The following is a description of a gene set: from publication Chen Y, Wang X (PMID 31504780) species: Homo sapiens Human Gene Set: MIR449B_3P Genes predicted to be targets of miRBase v22 microRNA hsa-miR-449b-3p in miRDB v6.0 with MirTarget v4 prediction scores > 80 (high confidence targets)., and this is the list of marker genes: TMEM178B, SLC17A5, FRAT1, PCDHA6, LTBP3, ZDHHC9, MMGT1, FGF13, P4HA2, KMT5B, IP6K1, CREBRF, VANGL1, DLX3, WASL, YWHAZ, PPP2R5C, ZNF711, GNA13, PCDHAC2, TMEM65, TM9SF2, PCDHA1, ZMYND11, GPR161, PCDHA7, RWDD1, CAP2, BLTP1, U2SURP, GRIK2, GAP43, DYNC1LI2, PIGU, SFTPA2, SEPTIN11, ZSWIM5, RB1CC1, POGZ, PCDHA4, PLXNA1, NKX2-2, PCDHA2, PCDHA11, CSRNP3, CBL, CLDN1, RSBN1, PPP3CB, MTF2, SLC43A2, PHF20L1, NFAT5, ZMYM2, LPL, ZNF385B, SORT1, IPO8, NSG2, MSI2, PTPN9, LRP8, PHACTR4, ATP8A2, PCDHA13, DEPP1, SRBD1, PCDHA12, TMCC1, GPR137C, SLITRK3, PCDHA10, SCAI, SRSF11 (serine and arginine rich splicing factor 11), TSPYL1 (TSPY like 1), STXBP6, COLEC12, GLCCI1, METTL14, TSNAX, RAB1A, ZNF518A, FOXD2 (NCBI Gene Id 2306), WDR6, XPO4, SAYSD1, BMAL2, SLC5A12, ZBTB25, UPRT, NR2C2, ZNF17, KIF1B, CDC37L1, GARIN1A, GNAZ, SLC39A10, ATP6AP1, NPPC, UCP3, GABARAP, NTPCR, DDC, STON2, UBA6, EPHA7, SMAD4, PCDHA5 (NCBI Gene Id 56143, protocadherin alpha 5), PCDHAC1, NPFFR2, CDH8, TAGLN2, NCAM2, PCDHA3, MSL1, KCNJ15, PRKACB, BLOC1S5, KPNA1, KDM4B, RPL22, CLDN10, CAMK2A